Given this list of marker genes GRIN3A, CAMK2B, TUBB6, TUBB4A, TUBA3C, CASK, TUBA3E, DLG2, TUBB8, TUBB2B, LRRC7, GRIN2B, DLG4, CAMK2G, APBA1, TUBA3D, CAMK2A, TUBB8B, TUBB4B, TUBAL3, LIN7A, NEFL, GRIN2A, KIF17, TUBB3, DLG3, DLG1 (discs large MAGUK scaffold protein 1), TUBA4B, TUBA8, GRIN2C (glutamate ionotropic receptor NMDA type subunit 2C), NBEA, LIN7B, GRIN3B, TUBA1B, TUBB2A (NCBI Gene Id 92919), LIN7C, TUBB1, ACTN2, TUBA1A, TUBA4A, GRIN1 (NCBI Gene Id 2902), CAMK2D, GRIN2D, TUBA1C (NCBI Gene Id 84790), here is a description of the gene set: studied in species Homo sapiens part of: Activation of NMDA receptors and postsynaptic events N-methyl-D-aspartate receptors (NMDARs) are tetramers that consist of two GluN1 (GRIN1) subunits and two subunits that belong to either the GluN2 (GRIN2) subfamily (GluN2A, GluN2B, GluN2C and GluN2D) or the GluN3 (GRIN3) subfamily (GluN3A and GluN3B). The GluN2/GluN3 subunits in the NMDA tetramer can either be identical, constituting an NMDA di-heteromer (di-heterotetramer), which consists of two subunit types, GluN1 and one of GluN2s/GluN3s, or they can be two different GluN2/GluN3 proteins, constituting an NMDA tri-heteromer (tri-heterotetramer), which consists of three subunit types, GluN1 and two of GluN2s/GluN3s.<br>NMDA tetramers assemble in the endoplasmic reticulum and traffic to the plasma membrane as part of transport vesicles. NMDA receptor subunits undergo N-glycosylation, which impacts their trafficking from the endoplasmic reticulum to the plasma membrane. Trafficking efficiency may vary among different subunits of NMDARs. Mechanistic details, such as glycosyl transferases involved and the type of sugar side chains added, are not known.<br>As there are eight splicing isoforms of GluN1, four different GluN2 and two different GluN3 proteins, many different combinations of NMDAR subunits are possible, but only a handful of distinct NMDAR receptors have been experimentally confirmed and functionally studied. The composition of NMDARs affects trafficking, spatial (including synaptic) localization, ligand preference, channel conductivity and downstream signal transmission. Prevalent NMDARs differ at different stages of neuronal development, in different regions of the central nervous system, and at different levels of neuronal activity. For review, please refer to Lau and Zukin 2007, Traynelis et al. 2010, Paoletti et al. 2013, Pérez-Otaño et al. 2016, Iacobucci and Popescu 2017. Reactome Pathway: Assembly and cell surface presentation of NMDA receptors